Given this list of marker genes RPS19, SRSF9, RPL17, RPS24, EBP, SNRPD2 (NCBI Gene Id 6633), EEF2, ACTG1, HMGN1, RACK1, PCBP1, RPS8, HMGN2, RPL11, EEF1B2, ATP5F1C, RPL27, CBFB, SUMO2, RHOA, TATDN2, UQCRC2, TBCB, DUT, UBA52, UQCRH, PSMB3, ATP5MC3, TIAL1, SNRPA1, RPL6, NONO, SNRPB, HNRNPK, RPL7, SNRPF, EIF4A1, CUL3, PSMA5, CSNK2B, SRSF2, COPS5, EIF4H, RPL21, BRD8, APRT, YWHAQ, SNRPE, YWHAZ (tyrosine 3-monooxygenase/tryptophan 5-monooxygenase activation protein zeta), SSR2, PPP1CC, SLC25A3, USP7, RPS23, BCLAF1, NCL, PSMB4 (proteasome 20S subunit beta 4), SRP14, NPM1, ZNHIT3, HNRNPM, NAP1L1, CNBP, RPL29, EPRS1, TRA2B, SNRPA, RPS3, COX6A1, EEF1G, PSME1, NACA, FRG1, SET, DHX9, DDX39B, IK, CLIC1, RPS3A, ATP5F1B, ILF2, NDUFA12, MAZ, TRIM28, HSP90AB1, POLR2G, RPL32, HMGB1, RPL10A, U2AF1, KHDRBS1, PSMA1, RPL4, APEX1, HNRNPA2B1 (heterogeneous nuclear ribonucleoprotein A2/B1), HNRNPU (NCBI Gene Id 3192), PPIA, DHX38, TMSB10, SAP18, RPL3, ATP5PB, SNRPD3, HNRNPA1, HSP90AA1, RPS27A, EIF4G2, PSMD6, PRMT1, TCP1, H2AZ1, H3-3A, ATP1B3, FXR1, RPL19, SUZ12, RPL9, RPS6, UFD1, CFL1, PTMA, EIF3F, RPL35A, SLC25A6, here is a description of the gene set: studied in species Homo sapiens Human Gene Set: GCM_ACTG1 Neighborhood of ACTG1 Neighborhood of ACTG1 actin, gamma 1 in the GCM expression compendium